Given this list of marker genes Ppp3cb, Vsnl1, Oga, Mir410, Cd38, Rhbdf2 (rhomboid 5 homolog 2), Mtnr1a, Ang6, Drd4, Baiap3, Orai1, Tiam1, Vps35, Slc8b1, Fga, Rapgef4, Abca12, Tfap2b, Il13, Lepr, Stim1, Rptor, Il1a, Per2, Hadh, Slc9b2, Atg7, Rph3al, Mmp13, Kcnq1, Capn10, Il6, Fam3d, Ep300, Ppard, Pcsk1, Ptpn11, Kif5b, Hcar2, Bad, Idh2, Tmed10, Cask, F2, F2rl1, Sirt6, Myt1, Rab34, Ncoa6, Crhr2, Ins1, Nlgn2, Mtnr1b, Ghsr, Madd, Gpr27, Acvr1c, C1qtnf3, Dnajc1, Tlr4, Ccl5, Gpld1, Ffar1, Tbc1d1, Kcnj6, Rab11fip5, Gnaq, Serp1, Sytl4, Golph3, Glp1r, Cd200, Ndufaf2, Adcy5, Irs1, Sec24a, Epha5, Irs2 (NCBI Gene Id 384783), Lep, Mup3, Prkcb, Anxa1, Cnr1 (cannabinoid receptor 1), Cacna1c, Malrd1, Fbn1, Sybu, Blk, Snap25, Anxa5, Cdk16, Fkbp1b, Psmd9, Pfkm, P2rx7, Myrip, Trpm4, Arf1, Gna11, Ttn, Pfkl, Wls, Ahi1, Trpc1, Gnas, Clock, Unc13b, Agt, Stx4a, Sri, C2cd2l, Nadk, Cartpt, Adam9, Hif1a, F2r, Foxa2, Tgfb3, Trem2, Crh, Tardbp, Ang2, Gpr68, Tgfb1, Ptger3, Klf7, Hmgn3, Apoe, Rest, Isl1, Rhbdd3, Ensa, Ang, Cela2a, Pde1c, Doc2b, Cacna1e, Acsl4, Prkce, Gipr, Prkar1a, Nnat, Ptpn23, Mcu, Ifnb1, Slc30a8, Pparg, Inhbb, Abcc8, Egfr, Syt4, Fto, Sirt3, Rfx6 (regulatory factor X, 6), Ier3ip1, Erp29, Gcg, Tnf (NCBI Gene Id 21926, tumor necrosis factor), Il12a, Gpr39, Ptger4, Gja1, Neo1, Pck2, Zfp384, Cyp51, Il12b, Cacna1d, Lrp5, Rab11fip3, Alox5, Sfrp1, Birc5, Nos1, Tunar, Gprc6a, Mlxipl, Pdx1, Rac1, Trpa1, Gnaz, Mup5, Pde3b, Rab11fip1, Syt9, Syt7, Myo18a, Hnf4a, Mpc2, Brsk2, Osbp, Bsg, Mup1, Ppia, Glul, Rfx3, Stxbp5l, Npff, Myh9, Kcnj11, Pim3, Pick1, Kcnn4, Dph3, Mup11, Myh10, Slc25a22, Nr1h3, Atp13a2, Nr1d1, Dynll1, Cd2ap, Fgb, Chga, Piwil4, Mir200a, Ptpmt1, Ang5, Dnm1l, Oprm1, Adtrp, Zbed6, Nr1h4, Eny2, Tm7sf3, Midn, Arf6, Ffar2, Abcg1, Ccn3, Cftr, Rsad2, Hmgcr, Gip, Efna5, Adcy8, Adra2a, Ins2, Mup2, Prkn, Gnai1, Apbb3, Slc12a2, Golph3l, Prkaca, Ifng, Prkcq, Uts2, Pde8b, Sirt1, Gper1, Nos2, Mir130a, Kcnb1, Krt20, Drd3, Ptprv (protein tyrosine phosphatase receptor type V), Nr1h2 (nuclear receptor subfamily 1, group H, member 2), Trpm5, Sergef, Ffar3, Tmed10-ps, Ang4, Ano1, Hnf1a, Tcirg1, Ppp3ca, Jak2, Trh, Gja5, Lrrc8a, Stxbp4, Fgg, Rap1gds1, Pde4c, Rbp4, Pla2g6, Ppid, Chrm3 (cholinergic receptor, muscarinic 3, cardiac), Trpm2, G6pc2, Myom1, Exph5, Plcb1, Igf1, Slc16a1, Sox4, Vamp8, Arrb1, Ghrl, Foxo1, Cpt1a, Srebf1, Tgfb2, Tlr2, Sirt4, Mup4, Srcin1, Arfip1, Map4k4, Camk2n1, Drd2, Nr0b2, Anxa7, Jagn1, Ucn3, Apbb1 (NCBI Gene Id 11785), Nmu, P3h1, Ptbp1, Casr, Lrp1, Il1b, Adora2a, Eipr1, Itpr1, Nkx6-1, Abat, Tmem132a, Glud1, Idua, Gnao1, Pard6a, Oxct1, C1qtnf12, F2rl2, Rhbdf1, Gck, Ucp2 (NCBI Gene Id 22228), Ankrd1, Sstr5, A1cf, Or51e2, Tcf7l2, Hcfc1, Aacs, Bmal1, Slc2a2, Vegfc, Frmd4a, Pfkfb2, Bglap2, Uqcc2, Sidt2, here is a description of the gene set: Any process that modulates the frequency, rate or extent of the controlled release of a protein from a cell. species: Mus musculus Mouse Gene Set: GOBP_REGULATION_OF_PROTEIN_SECRETION